Given this list of marker genes TBC1D20, USP9X, FANCF, GNB2, RBM10, BBS9, DKC1, STRA6, BUD23, BAZ1B, CHN1, RPL35, ZEB2, PIK3R2, RAF1, NPHP1, ARID1B, TBX22, RPS7, APC, RFC2, PBX1, RAD51, NCF1, BBS7, RECQL4, REST, BICRA, ADA2, DIS3L2, TMEM270, GTF2I, FANCL, LZTFL1, CLIP2, TTC8, MEOX1, RPS20, RBBP8, BBS12, XRCC2, DDX59, METTL27, HNF1B, RPS26, GRB10, FANCM, SMS, IQSEC2, CCBE1, EIF4H, FANCG, H19 (H19, imprinted maternally expressed transcript), SOX4, DNA2, GLI3, SCLT1, WDPCP, TCTN3, SMARCE1 (SWI/SNF related, matrix associated, actin dependent regulator of chromatin, subfamily e, member 1), FLII, MNX1, RPL8, WNT7B (Wnt family member 7B), RPL11, IFT74, SSR4, RPL15, SRY, BBS1 (Bardet-Biedl syndrome 1), HOXD13, CTU2, DYNC2LI1, AFF4, DSE, SMARCC2, RPS29, CDC42BPB, EBF3, ZMYM3, RPS28, RFWD3, MYCN, GDF6, ERCC4, ZFX, STAG1, MLXIPL, CHD7, ARID1A, CEP290, MKKS, GREB1L (GREB1 like retinoic acid receptor coactivator), TSR2, CD96, GDF3 (NCBI Gene Id 9573), RARB, WAC, SMARCA4, RAB18, BRIP1, LIMK1, KDM6A, BBS4, HMGA2, BBS5, BBS2, FANCI, ZMYM2, SON, DPF2, ZIC3, WNT4, MAP3K7, ARID2, TRIP13, CCNQ, XRCC4, TBL2, DDX6, RPS27, VPS37D, CCND2, LEMD3, RPS15A, POU6F2, PAX2 (NCBI Gene Id 5076), DNAJC30, FANCE, RAP1GDS1 (NCBI Gene Id 5910), RTTN, GPC3, UBE2T, PIK3CD, SPINK5, GTF2IRD1, BBS10, RPL18, PSMD12, BRAF, PORCN, BRCA2, HNRNPH1, STX1A, ELN (elastin), AKT3, PTPN11, HEATR3, TRIM32, SEMA3E, NRIP1, FAT4, SCAPER, RAD51C, RPL27, FUZ, POR, AFF3, JAM3, RPS17 (NCBI Gene Id 6218), MAFB, CHST14, DEAF1, SDCCAG8, KRAS, FGFR2, FANCA, SMOC1, EXTL3, IFT172, HNRNPU, RAB3GAP2, EBP, DDB1, ADAMTS3, RBM8A, ARL6, MRPS34, BRCA1, DSTYK (NCBI Gene Id 353293), FKBP6 (FKBP prolyl isomerase family member 6 (inactive)), ESCO2, COLEC10, FANCB, NRAS, RPL35A, GTF2IRD2, LRP4, SC5D, KNSTRN, SALL1, MCM5, KAT5, RAB3GAP1, SPECC1L, SALL4, CEP19, CFAP418, UBA2, HRAS, RPL26 (ribosomal protein L26), BBIP1, CAPN15, GATA1, SNRPB, FANCD2, IFT27, THOC6, MAD2L2, PALB2, TRIM28, BMPER, RPS24, SMARCD1, SOX11, WT1, RPL31, COLEC11, RAI1, CWC27, VANGL1, SMARCB1, DHCR7, DACT1, RPL9, RPL5, MCTP2, MKS1, CC2D2A, CHUK, SLX4, SF3B2, NIPBL, FGFR1, PUF60, FANCC, RPS10, RIPK4, UBE2A, DYRK1A, RPS19, KMT2D, here is a description of the gene set: An abnormal site of the kidney. studied in species Homo sapiens Abnormal localization of kidney Human Gene Set: HP_ABNORMAL_LOCALIZATION_OF_KIDNEY